Given this list of marker genes PIK3CA, INPP5E, BAP1, SMARCB1, TERT, PDGFB, NF2, AKT1, SMARCE1, SUFU, TRAF7 (NCBI Gene Id 84231), SMO, here is a description of the gene set: Intermittent clonic or tonic contraction of muscles supplied by facial nerve. Muscles are relaxed in between contractions. Hemifacial spasm Human Gene Set: HP_HEMIFACIAL_SPASM studied in species Homo sapiens